The following is a description of a gene set: species: Homo sapiens from publication Prots I, Skapenko A, Lipsky PE, Schulze-Koops H (PMID 21347372) Genes down-regulated in comparison of CD25+ regulatory T cell (Treg) treated with IL4 at day 7 versus CD25- T cells treated with IL4 at day 7. Human Gene Set: GSE24634_TREG_VS_TCONV_POST_DAY7_IL4_CONVERSION_DN CD25+ regulatory T cells develop in the thymus (nTregs), but may also be generated in the periphery upon stimulation of naive CD4 T cells under appropriate conditions (iTregs). The mechanisms that regulate the generation of peripheral iTregs are largely unknown. We used microarrays to gain insights into the molecular program of extrathymic Treg development., and this is the list of marker genes: ARAP1, CREG1, PHF1, KANK1, FADS1, PSAP, LILRB4, MMD (NCBI Gene Id 23531), CTSO, CHN2, PLAUR, ACSL1, PYGL, PLBD1, CD9, GOLGA8H, SLC47A1, STX4, TCF7 (transcription factor 7), CYP1B1, CXCR4 (C-X-C motif chemokine receptor 4), CYB5R1, MNT, JADE2, NLRP3, FGL2, C1orf54, GM2A, ASAH1, GPRASP1, CCL22, RELA, CTSC, MANBA, KMO, CSTA, KCTD12, TYMP, SLC27A3, ZSCAN18 (NCBI Gene Id 65982), RAB13, NACC2, RASGRP3, CDKN1A, ARL2BP, PLAU, HEXB, LPAR6, TMEM63A, ACP5, CTSL, SERPINE1, CD63, MREG, SLC2A5, TIMP2, IL18, MMP9, KYNU, FOS, MGLL, ATP1B1, KDSR (3-ketodihydrosphingosine reductase), RBM47, DCHS1, C1QA, CTSZ, CCDC88A, NRP1, TTC3, CKAP4, MSL1, FCGR2B, RGL1, ITM2C, LRP12, SHTN1, SIRPA, SLC1A3, RTN1, PLA2G15, ZFYVE16, FPR3, BASP1, PLLP, ST3GAL5, LARS1, ZNF415, BLNK, SNX2, IGFBP6, ZNF239, CRY2, NELL2, TSC22D1, TMEM51, ADAM9, CMKLR1, VPS11, MNDA, SYK, MARCO, LY9, NPL, CCL23, TYROBP, DCSTAMP, CD14, LPL, CTSV, RNF130, CTSS, STX2, GLG1, SLC38A6, RNASE1, LHFPL2, CYP27B1, TMEM176B, PDGFC, RAB20, GALNT12, CD209, SEMA3C, METTL1, TNFRSF10B, SCPEP1, CYBB, FEZ2, FTH1, UBE2W, GSN, SLC15A3, CRYBG1, C10orf95, BEX4, CCL24, CTSB, MAFF, TLR1, RBM6 (NCBI Gene Id 646559), FTL, CTSH, SCD, HLX, FN1, CCL17, GARRE1, SGPL1, PLA2G7, IFNGR2, ALOX5 (arachidonate 5-lipoxygenase), MMP12, SQSTM1, RHBDF2, WNT5A, PTPRE, TCF4, SAT1, QPCT, ALDH2, CYFIP1, IRF8, SLC2A6 (solute carrier family 2 member 6), DBP (NCBI Gene Id 1628), RHOQ, ZNF573, ARRB1, IFNGR1, CUX1, PPARD, CA2, FCGRT, SGSH, ENTR1, TEX2 (testis expressed 2), LEPROT, SLC11A2, POFUT2, RRAGD, INTS15, LYZ, CD68, LIPA, LGALS3, P2RY13, ZNF34, LY96, HNMT, PRDM4, HCK, PPFIBP2, CCL2, FNDC3B, SLC30A1, CD163, MEF2A, CHI3L1